The following is a description of a gene set: Platelet homeostasis Mouse Gene Set: REACTOME_PLATELET_HOMEOSTASIS species: Mus musculus, and this is the list of marker genes: Gng3, Nos3, Ppp2r5b, Gng13 (guanine nucleotide binding protein (G protein), gamma 13), Trpc6, Atp2b4, Trpc7, Pde2a, Itpr1, Gnb3, Itpr2, Ppp2cb, Ppp2r1a, Ptpn11, Slc8a1, Pde5a, Ppp2r5c, P2rx4, Irag1, Gnb4, Atp2a3 (NCBI Gene Id 53313), Calm3, P2rx3, Apob (apolipoprotein B), Ppp2r5a, Pafah2, Gng8, Fgr, Atp2b1, Sri, Gnb2, Gnb1, Pecam1, Ppp2r5e (protein phosphatase 2, regulatory subunit B', epsilon), Gng7, Calm2 (calmodulin 2), Pde1a, Atp2a2, Ppp2ca, Gng2, P2rx1, P2rx6, Ptpn6, P2rx2 (purinergic receptor P2X, ligand-gated ion channel, 2), P2rx5, Gng10, Ppp2r5d, Gngt1, Gng12, Prkg1, Gnas, Atp2b2, Gng5, Atp2a1, Slc8a2, Itpr3, Pde11a, P2rx7, Ptgir, Nos1, Pde1b, Gngt2, Calm1, Gnb5, Lrp8, Atp2b3, Pde9a, Gng4, Nos2, Mapk14, Pla2g4a, Slc8a3, Trpc3, Pde10a, Ppp2r1b, Gng11